The following is a description of a gene set: species: Homo sapiens Binding to chitin, a linear polysaccharide consisting of beta-(1->4)-linked N-acetyl-D-glucosamine residues. Human Gene Set: GOMF_CHITIN_BINDING, and this is the list of marker genes: CHI3L1, CTBS, CHIT1, OVGP1, CHIA, CHID1, CHI3L2, FIBCD1